The following is a description of a gene set: Mouse Gene Set: GOBP_INTERMEDIATE_FILAMENT_ORGANIZATION Control of the spatial distribution of intermediate filaments; includes organizing filaments into meshworks, bundles, or other structures, as by cross-linking. studied in species Mus musculus, and this is the list of marker genes: Nefm, Krt19, Krt23, Prph, Krt81, Krt16, Krt86, Mtm1, Krt2, Bfsp1, Bfsp2, Krt83, Krt35, Krt5, Krt79, Krt84, Krt31, Krt20, Krt82, Krt6a, Krt9, Krt12, Krt13, Krt85, Krt34, Krt27, Gm5478, Pkp2, Krt17, Bbln, Krt6b, Krt25, Krt71, Krt74, Krt80, Flg, Krt1, Agfg1, Krt77, Krt73, Krt4, Shh, Krt14 (NCBI Gene Id 16664), Krt75, Gfap, Eppk1, Krt40, Klhl24, Dreh (down-regulated in hepatocellular carcinoma), Krt32, Krt72, Krt7, Krt28, Gm5414, Des, Krt33a, Krt24, Krt78, Plec, Agfg2, Krt10, Krt76, Krt90, Krt33b, Pkp1, Krt36, Krt39, Ina, Tchh, Nefh, Nefl (NCBI Gene Id 18039), Krt87, Dsp, Krt26, Vim (NCBI Gene Id 22352), Krt15, Dnajb6, Krt42 (keratin 42)